Given this list of marker genes CASP3, IL18, CASP4 (caspase 4), GSDMD, IL1B, here is a description of the gene set: studied in species Homo sapiens Reactome Pathway: CASP4-mediated substrate cleavage Once activated, caspase-4 (CASP4) cleaves gasdermin D (GSDMD), which is also a substrate of CASP1, CASP5, and Casp11, a murine homolog of human CASP4/CASP5 (Shi J et al., 2015; Kayagaki N et al., 2015; Zhao Y et al., 2018; Wang K et al., 2020; Downs KP et al., 2020). This cleavage releases a cytotoxic N-terminal fragment, GSDMD(1–275), which forms pores in lipid membranes, leading to pyroptosis, and a C-terminal fragment, GSDMD(276–484), which normally inhibits pore formation by binding the N-terminus (Shi J et al., 2015; Liu X et al., 2016; Ding J et al., 2016; Sborgi L et al., 2016; Aglietti RA et al., 2016; Liu Z et al., 2019; Yang J et al., 2018; Kuang S et al., 2017; Wang K et al., 2020). In addition, CASP4 (and CASP5) efficiently processes pro-interleukin-18 (pro-IL-18) at aspartic acid residue D36 to generate its mature, biologically active form (Shi X et al., 2023; Devant P et al., 2023; Exconde PM et al., 2023; reviewed by Exconde PM, 2024). Structural analyses revealed that this cleavage relies on a bivalent recognition mechanism, in which pro-IL-18 binds caspase-4 through two interfaces: the protease exosite binds a hydrophobic pocket within pro-IL-18, while the active site of CASP4 engages charged residues located within and adjacent to the tetrapeptide recognition motif in the pro-domain (Shi X et al., 2023; Devant P et al., 2023). In contrast, CASP4- and CASP5-mediated cleavage of pro-IL-1β at D27 produces an inactive fragment that lacks receptor-stimulating activity (Exconde PM et al., 2023; reviewed by Exconde PM, 2024). An alternative CASP4-mediated cleavage at D116, the canonical pro-IL-1β activation site, has been observed but occurs with lower efficiency comparing to pro-IL-18 processing (Bibo-Verdugo B et al., 2020; Chan AH et al., 2023; Devant P et al., 2023). CASP4 may also contribute to pro-IL-1α processing and maturation, though this remains less well defined (Casson CN et al., 2015; Wiggins KA et al., 2019). Mature IL-1 family cytokines are released through GSDMD pores, amplifying the inflammatory response in mammals (Shi J et al., 2015; Kayagaki N et al., 2015; reviewed by Broz P et al., 2020; Liu X et al., 2021).<br><br> part of: Non-canonical inflammasome activation